The following is a description of a gene set: Human Gene Set: GOBP_MESENCHYMAL_STEM_CELL_DIFFERENTIATION species: Homo sapiens The process in which a relatively unspecialized cell acquires specialized features of a mesenchymal stem cell. A mesenchymal stem cell is a cell that retains the ability to divide and proliferate throughout life to provide progenitor cells that can differentiate into specialized mesenchymal cells., and this is the list of marker genes: CTNNB1, SLC4A11, FZD1, PDGFRA, SOX6, GSK3B, LTBP3, NR6A1, SOX5, MIR346, WNT3, REST, NDUFS6 (NADH:ubiquinone oxidoreductase subunit S6), SOX9